Given this list of marker genes SLC25A6, ACAA2, BID, FZD9, SLC25A5, VDAC2, GSK3B, LAPTM5, SLC9A1, MPV17L, CHCHD10, ZNF205, BCL2L1, ATF2, LRRK2 (NCBI Gene Id 399472), HSPA1A, BCL2L11, GSK3A, SIVA1, BLOC1S2, SPG7, MYLK3, SLC25A4, MIR142, MIR29C, PPIF, DEFA5, RHOT2, BOK, TMEM102, BAK1, TP53, EYA2, JAM3, MUL1, RHOT1, BNIP3L, HIP1R, TMEM14A, SLC25A31, STPG1, GCLC, BNIP3, MIR29B1, RTL10, SLC35F6, BAX, MIR29A, IER3, ATP5IF1, here is a description of the gene set: Any process that activates or increases the frequency, rate or extent of the passage or uptake of molecules by a membrane. Human Gene Set: GOBP_POSITIVE_REGULATION_OF_MEMBRANE_PERMEABILITY species: Homo sapiens